The following is a description of a gene set: part of: TCR signaling species: Mus musculus electronically inferred by orthology from the curated human pathway This event has been computationally inferred from an event that has been demonstrated in another species.<p>The inference is based on the homology mapping from PANTHER. Briefly, reactions for which all involved PhysicalEntities (in input, output and catalyst) have a mapped orthologue/paralogue (for complexes at least 75% of components must have a mapping) are inferred to the other species. Reactome Pathway: Generation of second messenger molecules, and this is the list of marker genes: Lck, Lat, Grap2, Itk, Lcp2, Cd3g, Plcg2, Pak3, Cd3d, Cd3e (NCBI Gene Id 12501)